Given this list of marker genes DYNC2I2, BMP4, CCDC28B, B9D2, BBS1, TMEM237, WDR19, BBS12, PRKACB, TXNDC15, TMEM216, EVC2, LZTFL1, PLAA, SC5D, DYNC2H1 (dynein cytoplasmic 2 heavy chain 1), TCTN1, IFT27, DHCR7, EVC, LBR, ARL6, CD96, B9D1, BBS2, SCNM1, ZNF141, GLI3, CIBAR1 (NCBI Gene Id 730572), HOXD13, MKS1, DYNC2LI1 (NCBI Gene Id 51626), DYNLT2B, TMEM231, KIAA0753, RPGRIP1L, DDX59, NEK1, RAB34, SETD5, C2CD3, OFD1, SMOC1, KIAA0825 (KIAA0825), IFT80 (intraflagellar transport 80), TMEM67, IFT74, IFT172, RPGRIP1, TCTN2, CC2D2A, NPHP3, IQCE, MAX, PDE6D, SUFU, MKKS, CEP120, INPP5E, TCTN3 (NCBI Gene Id 26123), BBS9, EXTL3, DYNC2I1, OTUD5, TMEM107, SMO, IFT140, KIF7, CSPP1, CEP290, TTC21B, here is a description of the gene set: Postaxial foot polydactyly Human Gene Set: HP_POSTAXIAL_FOOT_POLYDACTYLY Polydactyly of the foot most commonly refers to the presence of six toes on one foot. Postaxial polydactyly affects the lateral ray and the duplication may range from a well-formed articulated digit to a rudimentary digit. studied in species Homo sapiens